The following is a description of a gene set: studied in species Homo sapiens Human Gene Set: REACTOME_NR1H2_NR1H3_REGULATE_GENE_EXPRESSION_LINKED_TO_TRIGLYCERIDE_LIPOLYSIS_IN_ADIPOSE NR1H2 & NR1H3 regulate gene expression linked to triglyceride lipolysis in adipose, and this is the list of marker genes: RXRA, NR1H2, NR1H3, RXRB, PLIN1